Given this list of marker genes Ephb1, Slc13a5 (NCBI Gene Id 405903), Kbtbd2, Ubl3, Adcy3, Mtbp, Ndst3, Tespa1, Zfp260, Ntrk2, Mtf1, Kpna1, Wac, Tcof1, Eif2b5, Rps6ka4, Mlec (malectin), Bcl11a, Clec3b, Zfp518b, Oxr1, Necap1, Zbtb12, Sox7, Glg1, Celf4, Aak1, Slc35f2, Usp6nl, Cdk5r1, Cplx1, Cep97, Zfand5, Hes2, Milr1, Spring1, Elmod2, Cd69, Acsl1, Ddr2, Rims2, Atrn (attractin), Preb, Slitrk1, Nt5c2, Map3k2, Hacl1, Mthfr, Spindoc, Tnip1, Gins3, Ankrd13a, Arglu1 (arginine and glutamate rich 1), Ccr5, Gm57852, Ccpg1, Jph3, Ndst2, Hip1r, Clspn, Clic5, Acap3, Csf3, Fam3d, Mtmr4, Plekhh2, Zfp46, Dnajc7, Prrc2b, Ammecr1l, Atp2b2, Mpz, Nopchap1, Habp4, Thpo, Aqp4, Fhl1, Kpna6, Atxn1l, Rgl2, Extl3, Macir, Ino80d, Synj1, Ccser1, Greb1l, Clip3 (NCBI Gene Id 76686), Plod1 (NCBI Gene Id 66472), Eif4ebp2, Cd200, Ears2, Fgfbp3, Dglucy, Kif3b, Ythdf1, Fign, Cracdl, Phf21a, Rmi2, Stt3b, Slc8a3, Pvalb, Ccny, Gpc6, Xirp2, Tpmt, Mcm4, Cds2, Slc2a13, Sertad2, Vstm2a, Fchsd2, Scai, Poglut1, Caln1, Cdkn2a, Nudt2, Cpxm2, Grik3, Nsun2, here is a description of the gene set: from publication Chen Y, Wang X (PMID 31504780) studied in species Mus musculus Genes predicted to be targets of miRBase v22 microRNA mmu_miR_7083_3p in miRDB v6.0 with MirTarget v4 prediction scores > 80 (high confidence targets). Mouse Gene Set: MIR_7083_3P